Given this list of marker genes Clec4d, Dpm1, Mrc1 (NCBI Gene Id 99352), Cln5 (NCBI Gene Id 211286), Asgr1, Clec4a3, Man2b1, Cd209d, Cd209c, Cd209f, Clec4a4, Clec4n, Clec4g, Mbl1, Bsg, Acr, Clec10a, Clec4a2, Cd209e, Mgl2, Cd209a, Lman2, Clec4a1, Colec10, Lman2l, Colec11, Lman1, Lman1l, Cd209b, Igf2r, Asgr2, Manba, Mbl2, here is a description of the gene set: studied in species Mus musculus Mouse Gene Set: GOMF_D_MANNOSE_BINDING Binding to mannose, a monosaccharide hexose, stereoisomeric with glucose, that occurs naturally only in polymerized forms called mannans.